The following is a description of a gene set: Any process that activates or increases the frequency, rate or extent of extrinsic apoptotic signaling pathway in absence of ligand. species: Mus musculus Mouse Gene Set: GOBP_POSITIVE_REGULATION_OF_EXTRINSIC_APOPTOTIC_SIGNALING_PATHWAY_IN_ABSENCE_OF_LIGAND, and this is the list of marker genes: Unc5b, Wwox, Tgfb2, Htra2, Ppp2r1b, Ret (ret proto-oncogene), Ctnna1, Ppp2r1a, Dapk3, Srpx, Nf1, Jak3, Ppp1ca, Inhba